Given this list of marker genes TNFRSF1A, APAF1, CASP9, CD247, TRADD, CHUK, BIRC3, MAP3K14, TNF, CASP2, DFFB, BCL2, CRADD, FASLG, DFFA, MAP2K7, CASP8, CASP3, NFKB1, NFKBIA (NFKB inhibitor alpha), DAXX, BAG4, CFLAR, FADD, CASP7, RELA, CYCS, BID, TRAF1, FAS, MAP3K5, CASP6, MAPK8, RIPK1, TRAF2, here is a description of the gene set: HIV-1 Nef: Negative effector of Fas and TNF-alpha Human Gene Set: PID_HIV_NEF_PATHWAY from publication Schaefer CF, Anthony K, Krupa S, Buchoff J, Day M, Hannay T, Buetow KH (PMID 18832364) species: Homo sapiens